Given this list of marker genes HSD3B2, CIRBP, EIF4A1, DIO2, MFSD12, MACROH2A1, CHAD, ZNF22, COX5A, ELAPOR2 (endosome-lysosome associated apoptosis and autophagy regulator family member 2), AKNAD1, SCARB1, HSPA12B, CARD19, CTC1, P2RX1, GJB1, RSPH3, AGO4, RGS1, FOXRED2, TGFB1, PRMT8, MFGE8, INAFM1, PPP2R5D, BASP1, C8A, GTSF1, LEP, STEAP2, NXF2, CRB3, PPA2, RAD50, CDH10, PAK6, FXYD6, SLC16A2, DMBX1, LSM7, TRIM44, BCR (BCR activator of RhoGEF and GTPase), TRAIP, SOX12, KRT8, EFHC2, ABLIM3, ST6GALNAC6, FES, RNF217, SYCP1, AMPD2, CCER1 (coiled-coil glutamate rich protein 1), MRPS28, GFI1B, NCAPG, CHAF1B, MYOF (NCBI Gene Id 26509), STAG3, PROX2, OR10AD1, GMPR, INCENP, PCDH7, DYNLT2B, VLDLR, CCL21, ASAP2, GSTM2, PPIA, ZNF518B, CLSTN2, XRCC2, EIF5A, MAGEL2, WWOX, MYCT1, FAM110A, PHKA1, DLG3, DOCK7, GAD1, SPMIP9, PDE11A (phosphodiesterase 11A), UNC13B, NEK2, CHKA, SMC1B, SYNGR1, PAICS, BTK, OPRM1, GDAP1L1, PIH1D2, ATAD5, HAND2, HP, SIRPA, PDZK1IP1, HAGHL, CBX5, ACSM3, TMEM39A, BUB1, SERINC3, LAIR1, PHGDH, CIT, GTF2IRD1, LMNB2, CAPZA3, ERCC6L, E2F1, GJA1, PCNT, UQCC6, AARSD1, COL4A2, CIMAP1B, CENPF, PRR12, DGCR6, CXXC5, ORC6, GADD45A, CIP2A, WFDC2, ATG4C, EMILIN2, PCDH10, TRIM40, DTNBP1, PXT1, B3GNT8, ZFHX3, NRM, PRSS58, MC5R, BICDL2, GNA15, TMEM41A, ALDOC, LMNB1, FBXW12, COL27A1, CBLN2, SNX22, C9, NPTX1 (NCBI Gene Id 4884), CSGALNACT1, FXYD2, NR4A2 (NCBI Gene Id 4929), DNM1, SMARCC1, CACNA2D1, AQP4, SUMO3, TMEM38B, SLC7A8, PPP1R1A (protein phosphatase 1 regulatory inhibitor subunit 1A), ANKRD13B, RNASE2, CKAP2, CA9, EDIL3, RACGAP1, KIF23, ANXA4, CHRNA5, TSEN2, P4HB, BAG6, ZDHHC16, WNT6, MCCC2, SGSM3, RAC3, CRTAP, AIRE, CHRNA6, H2AZ1, GPR17, MDFI, CDK4, FOXF1, RTKN, AP2A1, CCDC54, GATAD1, HDGF, ACVR2B, IL11RA, PEX7, VAMP5, MAPK6, NEDD4, MOV10, DEPTOR, PTMS, here is a description of the gene set: from publication Kim TD, Terwey TH, Zakrzewski JL, Suh D, Kochman AA, Chen ME, King CG, Borsotti C, Grubin J, Smith OM, Heller G, Liu C, Murphy GF, Alpdogan O, van den Brink MR (PMID 18178870) Transcriptional response of murine allogeneic T cells (B10.BR) after stimulation with different organ-derived (spleen, liver, peripheral and mesenteric lymph nodes) dendritic cells (C57BL/6) in vitro species: Homo sapiens Genes up-regulated in allogeneic T cells after stimulation with dendritic cells from: liver versus mesenteric lymph nodes (mLN). Human Gene Set: GSE5503_LIVER_DC_VS_MLN_DC_ACTIVATED_ALLOGENIC_TCELL_UP